Given this list of marker genes COL1A1, ACTB, SPTBN1, COL5A1, DHX30, MED12L, ACTG1, KCTD1 (NCBI Gene Id 284252), FRMD4A, ZNHIT3, ADAMTS2, GSN, SNX14, COL5A2, SHANK3, KNSTRN, SLC29A3, SLC35C1, KPTN, FOXG1, PSPH, RIN2, EFEMP1 (NCBI Gene Id 399564), PEX2, AIP, POU4F1, SOX18, RBMX, FBXO11, ANTXR1, KAT6A, TGFBI, CAMTA1, GPR101, PIK3CD, CDH11, PEX5, GNPTAB, XPNPEP2, here is a description of the gene set: Palpebral edema species: Homo sapiens Edema in the region of the eyelids. Human Gene Set: HP_PALPEBRAL_EDEMA